Given this list of marker genes MRPL18, SERPINA3, PRPS1, DDX21, ABCF1, FAM111A, POLA2, FEN1, EMB, HAT1, HMGA1, PYHIN1, ASF1B, CDC6, POLD1, HMGB2, PGP, ECM1, CDCA7, GRWD1, MCM5, ASS1, RNASE3, MSH6, NAP1L4, CHAF1B, MCM4, HELLS, DNMT1, MCM3, MCM7, MCM6, DUT, VCAN (NCBI Gene Id 7902), IFRD2, SMC2, ABCF2, SNX5, RAD51, RRM2 (NCBI Gene Id 6241), here is a description of the gene set: from publication Burton GR, Guan Y, Nagarajan R, McGehee RE Jr (PMID 12137940) Cluster 4: genes maximally expressed at 16 h time point during differentiation of 3T3-L1 fibroblasts into adipocytes in response to adipogenic hormones. The molecular mechanisms that regulate cellular differentiation during development and throughout life are complex. It is now recognized that precise patterns of differentially expressed genes ultimately direct a particular cell toward a given lineage and many of these are regulated during the earliest stages of differentiation. Using a microarray-based expression analysis, we have examined gene expression profiles during the first 24 h of 3T3-L1 adipocyte differentiation. RNA was isolated at times 0, 2, 8, 16, and 24 h following stimulation of differentiation and hybridized in duplicate to high density Affymetrix microarray gene chips containing a series of 13,179 cDNA/expressed sequence tag (EST) probe sets. Two hundred and eighty-five cDNA/ESTs were shown to have at least a fivefold change in expression levels during this time course and both hierarchical and self-organizing map clustering analysis was performed to categorize them by expression profiles. Several genes known to be regulated during this time period were confirmed and Western blot analysis of the proteins encoded by some of the identified genes revealed expression profiles similar to their mRNA counterparts. As expected, many of the genes identified have not been examined in such a critical time period during adipogenesis and may well represent novel adipogenic mediators. Human Gene Set: BURTON_ADIPOGENESIS_PEAK_AT_16HR species: Mus musculus